The following is a description of a gene set: Reactome Pathway: Clathrin-mediated endocytosis species: Homo sapiens Clathrin-mediated endocytosis (CME) is one of a number of process that control the uptake of material from the plasma membrane, and leads to the formation of clathrin-coated vesicles. CME contributes to signal transduction by regulating the cell surface expression and signaling of receptor tyrosine kinases (RTKs) and G-protein coupled receptors (GPCRs). Most RTKs exhibit a robust increase in internalization rate after binding specific ligands; however, some RTKs may also exhibit significant ligand-independent internalization. CME controls RTK and GPCR signaling by organizing signaling both within the plasma membrane and on endosomes. CME also contributes to the uptake of material such as metabolites, hormones and other proteins from the extracellular space, and regulates membrane composition by recycling membrane components and/or targeting them for degradation. <br><br><br>Clathrin-mediated endocytosis involves initiation of clathrin-coated pit (CCP) formation, cargo selection, coat assembly and stabilization, membrane scission and vesicle uncoating. Although for simplicity in this pathway, the steps leading to a mature CCP are represented in a linear and temporally distinct fashion, the formation of a clathrin-coated vesicle is a highly heterogeneous process and clear temporal boundaries between these processes may not exist (see for instance Taylor et al, 2011; Antonescu et al, 2011; reviewed in Kirchhausen et al, 2014). Cargo selection in particular is a critical aspect of the formation of a mature and stable CCP, and many of the proteins involved in the initiation and maturation of a CCP contribute to cargo selection and are themselves stabilized upon incorporation of cargo into the nascent vesicle.<br><br><br><br>Although the clathrin triskelion was identified early as a major component of the coated vesicles, clathrin does not bind directly to membranes or to the endocytosed cargo. Vesicle formation instead relies on many proteins and adaptors that can bind the plasma membrane and interact with cargo molecules. Cargo selection depends on the recognition of endocytic signals in cytoplasmic tails of the cargo proteins by adaptors that interact with components of the vesicle's inner coat. The classic adaptor for clathrin-coated vesicles is the tetrameric AP-2 complex, which along with clathrin was identified early as a major component of the coat. Some cargo indeed bind directly to AP-2, but subsequent work has revealed a large family of proteins collectively known as CLASPs (clathrin- associated sorting proteins) that mediate the recruitment of diverse cargo into the emerging clathrin-coated vesicles. Many of these CLASP proteins themselves interact with AP-2 and clathrin, coordinating cargo recruitment with coat formation. <br><br><br>Initiation of CCP formation is also influenced by lipid composition, regulated by clathrin-associated phosphatases and kinases. The plasma membrane is enriched in PI(4,5)P2. Many of the proteins involved in initiating clathrin-coated pit formation bind to PI(4,5)P2 and induce membrane curvature through their BAR domains. Epsin also contributes to early membrane curvature through its Epsin N-terminal homology (ENTH) domain, which promotes membrane curvature by inserting into the lipid bilayer. <br><br>Following initiation, some CCPs progress to formation of vesicles, while others undergo disassembly at the cell surface without producing vesicles. The assembly and stabilization of nascent CCPs is regulated by several proteins and lipids.<br><br><br>Maturation of the emerging clathrin-coated vesicle is accompanied by further changes in the lipid composition of the membrane and increased membrane curvature, promoted by the recruitment of N-BAR domain containing proteins. Some N-BAR domain containing proteins also contribute to the recruitment of the large GTPase dynamin, which is responsible for scission of the mature vesicle from the plasma membrane. After vesicle scission, the clathrin coat is dissociated from the new vesicle by the ATPase HSPA8 (also known as HSC70) and its DNAJ cofactor auxilin, priming the vesicle for fusion with a subsequent endocytic compartment and releasing clathrin for reuse. part of: Membrane Trafficking, and this is the list of marker genes: ACTR2, DNM3, EPS15L1, ARPC1A, COPS3, ARRB2, CLTC, ARF6, AGTR1, KIAA0319, EPGN, APOB, PICALM, GAPVD1, AVPR2, UBA52, RAB5B, REPS2, COPS5, FNBP1, TF (transferrin), SYT1, ACTG1, IGF2R, FZD4, TGFA, UBQLN1, EPN2, SYT9, EPS15, ARRB1, VAMP2, NEDD8, SYNJ1, STON1, PIP5K1C, PACSIN3, SLC2A8, OCRL, CTTN, AAK1, CHRM2, SLC18A3, GRK2, NECAP1, TRIP10, COPS8, SYNJ2, CD4, PIK3C2A, EGF (epidermal growth factor), DVL2, ITSN2, COPS2, SNX18, AP2A1, BTC, RAB5A, STAM2, CBL, SNAP91, COPS7B, COPS6 (COP9 signalosome subunit 6), IL7R, TOR1B, LDLRAP1, RAB5C, COPS7A, ACTR3, AREG, VAMP8, HSPA8, BIN1, AGFG1, REPS1, EREG, PACSIN2, GRB2, CD3G, CLTA, AP2M1 (NCBI Gene Id 1173), DAB2, TGOLN2, STAM, HBEGF, AP2A2, SYT11, CFTR, ARPC3, EPN1, AMPH (amphiphysin), CD3D, SNX9, SGIP1 (NCBI Gene Id 84251), PACSIN1, HGS, DNM1, EGFR, HIP1R, RPS27A, FCHO1, VAMP7, ADRB2, GRK3, AVP, TFRC, LRP2, HIP1, SCARB2, DNM2, SH3KBP1, DNAJC6, CLTB, SH3GL1, M6PR, SYT8, ARPC2 (actin related protein 2/3 complex subunit 2), AP2S1, GPS1, UBQLN2, WASL (WASP like actin nucleation promoting factor), NECAP2, UBC, VAMP3, LDLR, SH3GL2, GAK, ARFGAP1, ITSN1, ACTB, WNT5A, SH3GL3, VAMP4, SYT2, FCHO2, TACR1, COPS4, ARPC5, UBB, FNBP1L, AP2B1, STON2, TOR1A, ARPC4, CLTCL1